The following is a description of a gene set: part of: Switching of origins to a post-replicative state electronically inferred by orthology from the curated human pathway Reactome Pathway: CDK-mediated phosphorylation and removal of Cdc6 This event has been computationally inferred from an event that has been demonstrated in another species.<p>The inference is based on the homology mapping from PANTHER. Briefly, reactions for which all involved PhysicalEntities (in input, output and catalyst) have a mapped orthologue/paralogue (for complexes at least 75% of components must have a mapping) are inferred to the other species. studied in species Mus musculus, and this is the list of marker genes: Ccne2, Psmc4, Cdc6, Ubb, Psmc5, Psmd12, Psmb7, Ube2c, Fzr1, Cdc23, Anapc15, Psmc6, Psma4, Psmb6, Psma7, Psmd1, Psmd13, Ube2s, Rps27a, Psma6, Psmd7, Psma5 (proteasome subunit alpha 5), Psma2, Ccna1, Psmc1, Psmb4, Psmc3, Anapc2, Psma1, Anapc7, Psmc2, Ube2e1, Ube2d1 (ubiquitin-conjugating enzyme E2D 1), Psmb5, Anapc10, Psma3, Psmd6 (proteasome (prosome, macropain) 26S subunit, non-ATPase, 6), Cdc26, Ccne1